The following is a description of a gene set: species: Homo sapiens TCA cycle nutrient use and invasiveness of ovarian cancer Human Gene Set: WP_TCA_CYCLE_NUTRIENT_USE_AND_INVASIVENESS_OF_OVARIAN_CANCER, and this is the list of marker genes: JAK1, STAT3, MAPK3, MAPK1, EGFR